The following is a description of a gene set: Mouse Gene Set: GOMF_PROTEIN_HOMODIMERIZATION_ACTIVITY Binding to an identical protein to form a homodimer. studied in species Mus musculus, and this is the list of marker genes: Fbxo4, Tmem192, Rnf8, Nr2c1, Diaph3, Ugt1a7c, Nectin2, Arnt, Hspb8, Nog, Gyg1, Syt6, AY761185 (cDNA sequence AY761185), Nacc2, Prkra, Hnf1b, Mid2, Syt3, Lpl, Uxs1, Cer1, Adra2c, Trim12a, Rrm2, Defa5, Ugt1a8, Lrp4, Stk4, Ugt1a6b, Tpst2, Gnptg, Idh1, Fut9, Grm6, Defa42, Pdlim4, Cryl1, G6pdx, Pon1, Pdcd10, Pank1, Schip1, Cars1, Lct, Sting1, Cep43, Top2a, S100a10, Acot7, Birc5, H2-M10.6, Ntrk1, Mdh2 (NCBI Gene Id 17448), Kyat1, Ceacam1, Wwtr1, Wars1, Ceacam2, Pgrmc1, Stub1, Flrt3, Pex11b, Carnmt1, S100a5, Slk, Ide, Psph, Sds, Ucp2, Blm, Hsd11b1, Eno1, Sod1, Tenm2, Slc5a5, Col9a3, Vps25, Calcoco2, Chuk, Hand1, Zbtb7b, Defa37, H2-Q2, Trim30b, Gen1, Il17a, Usf2, Eif2ak1, Ttn, Sgta, Rabl3, Kit, Glce, Rtn4, Gucy2e, Jam3, Stard3, Masp1, Defa17, Amhr2, H2-M2, Oxa1l, Sgtb, Tpst1, Dars2, Ang2 (angiogenin, ribonuclease A family, member 2), Cacybp, Akt1, Abcd1, Jdp2, Park7, Myom1, Abcg3, H2-Q7 (histocompatibility 2, Q region locus 7), Miga1, Kcnip3, Aox3, Gadd45a, Ces1c, Mmut, Nadk2, Nkx2-5, Trnt1, Aoc1l1, Pcyt1a, Bnip3l, Trex1 (NCBI Gene Id 22040, three prime repair exonuclease 1), Slc25a14, Cby1, Miga2, Tbx15, Hpgds, Tpr, Xpa, Septin12, Sppl2a, Fmr1, Syt4, Shmt1 (serine hydroxymethyltransferase 1 (soluble)), H2-M10.1, Gbp5, Defa22, Zdhhc3, Supv3l1, Bhlhe40, Mff, Chmp4b, Mstn, Adrb3, S100z, Defa2, Flt1, Gsta13, Csf1r, Cadm1, Mtmr1, Adrb2, Zbtb1, Csf1, Hnf4a (hepatic nuclear factor 4, alpha), Dgkd, Pkd2, Dgat2, Defa43, Hps4, Septin5, Thap1, Acp3, Cda, Eno1b, Stc2, Ptprt, Sohlh2, Efr3a, Stk19, Dgcr8, Sppl2c, Cltrn, Tfrc, Mad2l1, Defa27, Rabep1, Gsta2, Pitx2, Xcl1 (NCBI Gene Id 98422), Cd247, Hmox1, Stom, H2-Q1, Tenm1, Atp2a1 (NCBI Gene Id 11937), Jaml, Trim5, Gstm1, Aoc1l3, Zdhhc2, Syne1, H2-M3, Tnnc1, Mgat4a (NCBI Gene Id 320137), Abcb9, Ugt1a6a, Acsl6, Timm9, Banf1, Cd4, Impa1, Tbx18, Tymp, Cisd2, Kif20b, Naa60, Terf1, Dck, Cep135, Pdk2, Pecam1, Sppl2b (signal peptide peptidase like 2B), Pon3, Slc25a27, Abcg4, Defa3, St3gal2, Bok, Xpnpep3, Axin1, Dscaml1, Fzd4, Creb3l3, Chmp1a, Cln6 (NCBI Gene Id 76524), Slc11a1, Cant1, Defa31, Pkm, Appl2, Mbl1, Kynu, Vil1, Tssk4, Smim1, Fzd9, Bax, Card9, Ikbkg, Defa20, Zbtb16 (zinc finger and BTB domain containing 16), Gdf15, Rab11fip4, Apoa1, Thrsp, Apoa2, Npc1l1, Terf2, Thbs1, Fcer1g, Defa41, Tmigd1, H2-Q6, Setmar, Odc1 (NCBI Gene Id 18263), Nrf1, Adipoq, Pdgfa, Paxx, Dnph1, Aldh1a3, Abcd3, Nr0b2, Phb2, Defa29, Slit2, Tyms, Tyrobp, Cenpf, Gpd1l, Csn1s2b, Camk2a, Snrpc, Ripk2, Psmf1, Map3k13, Ext1, Tpi1, Amelx, Nqo2, Thra, Rdh5, Kcnn4, Sirt6, S100a1, Bst2, Ssbp1, Mkln1, H2-M10.4, Smchd1, Rbm11, Tbc1d22a, Golga5, Defa36, Srm, Cdsn, Nr2f2, Pip4k2a, Bmpr1a, Trex2, Kcnn2, Ugt1a9 (NCBI Gene Id 394434), Rasip1, Bnip3, Tarbp2, Atf2, Smad4, Stk10, Chrna7, Snx6, Chek2, Aimp1, Crppa, Myh9, Gimap7, Dab2ip, Irak2, Col9a1, Tbx1, Ang4, Grpel2, Ano1, Dnm1l, Syndig1, Actn4, Xpnpep1, Tars2, Prph2, Izumo3, Pou3f3, Daxx, Dusp29, Camk2d (NCBI Gene Id 77170), Prps2, Mmachc, Ang, Pdcd6ip, Morc2a, Pth1r, Tenm3, Tpcn1, Tert, Cat, Apoa4, Dnttip1, Enpp1, Zbtb38, H2-M5 (histocompatibility 2, M region locus 5), Dclre1b, Uba5, Rraga, Aoc1, Psap, Aldh3a2, Agxt, Gca, Nfs1, Tyw5, Ahr, Ankrd11, Endog, Ctbp1, Gstz1, Mecom, Inhbb, Hspb1, Cebpa, Fgfr1, Npm1, Nr0b1, Mef2d, Wrn, Ccdc103, Nectin3, Nr6a1, Ptpa, Mixl1, Xdh, App (amyloid beta precursor protein, NCBI Gene Id 319425), St6gal1, Gdnf, Txn1 (thioredoxin 1), Nudt16, Ficd, Casq2, Rap1gap, Gsta1, Mvd, Bcl11a, Cgas, S100a13, Cyp2r1, Dpp4, Dst, Ccl5, Pex7, Glb1, Epm2a, Hip1r, Tgfb2, Dapk3, Slc4a1, Nos2 (NCBI Gene Id 18126), Mtpap, Glipr2, Hes1, Tenm4, Cryab, Defa32, Ikzf3, Qtrt1 (queuine tRNA-ribosyltransferase catalytic subunit 1), Lrp6, Ghr, Pank3, Defa25, Crym, Ano6, Bak1, Srr, Clec2f, Dpyd, Npr3, Bcl10, Ercc5, Defa40, Mgat2, Gid8, Aox4, Ugt1a5, Add2, Ambp, Defa28, Alx1, Ern1, Spr, Trim9, Trp53bp2, Ruvbl2, Zfp397, Slc51a, Jchain, Tesc, Impa2, Iscu, F11r, Rab11fip2, Papss1, Rag1 (recombination activating 1), Trim30d, Apoe, Trim8, Fxr2, Irak1, Scarb2, Dnm1, Dpy30, Hsp90ab1, Rab11fip3, Aoc1l2, Zfp318, Tpm4, Tyrp1, Pln, Defa24, Cep131, Gbp2, Myom3, Atic, Ptpro, Gstm3, Exd1, H2-D1, Syt10, Fech, Psmd7, Pdgfra, Camk2b, Atg7, Mmaa, Foxp3, Pheta2, Cubn, Rbm44, Ect2, Slc33a1, Rpe, Srf, Rela, Sp100, Grhpr, Tpm1, Ndp (NCBI Gene Id 236713), Naga, Mfsd1, Bard1 (BRCA1 associated RING domain 1), Pdgfc, Cited1, G6pd2, Abcb10, Als2, Nudt21, H2-K1, Aox2 (NCBI Gene Id 213043), Hand2, Pld6, Il17f (NCBI Gene Id 96930), H2-M10.2, Tpm2, Hnf1a, Flna, Padi2, Trim30c, Cib2, Map3k11, Ces1b, Hook1, H2-Q10, Cylc1, Lrrfip1, Hsd17b1, Sh3glb1, Rchy1, Trim37, Mapk4, Hpd, Col9a2, Hars1, Abcb7, Elavl1, Nrbp1, H2-M11, Rnf40, Chka, Fgfr2, Adra2a, Gstm4, Clcn1, Eea1, S100a6, Tlr9, Klhl7, Gldc, Tcf3, S100b, Gale, Mzf1, Defa34, Serpinf2 (serine (or cysteine) peptidase inhibitor, clade F, member 2), Omg, Ntrk2, Cbs, Ptgs2, Irf3, Pheta1, Nr4a3, Abcg1, Kmt2a, Il6ra, Bcas1, Agr2, Atf3, Cpq, Rbpms, Defa39, Pdcd6, Defa26, Acox1, Prmt2, Wdr54, Kcnh2, Acox2, Snf8, Mag, Srgap2, Hhex, Hes6, Asmt, Hip1, Pafah1b2, Vapb, Stat3, Acod1, Nudt5, Nectin1, Sox6 (SRY (sex determining region Y)-box 6), Dgkh, Defa23, Tap2, Cdadc1, Vapa, Sp1, Defa35, Abcd2, Hif1an, Pdxp, Chmp4c (charged multivesicular body protein 4C), Zfp365, Mgll (monoglyceride lipase), Cr2, Hesx1, Irak3, Lrrk2, Erp29, Foxp2, Hsp90aa1, H2-T22, Hmgcs1, Twist1 (twist basic helix-loop-helix transcription factor 1), Bhlhb9, Nod1, Add1, Stat1, Morc2b, Galm, Prdm9, Ppcs (NCBI Gene Id 67987), Mtus2, Grpel1, Ocm (oncomodulin), Vwa1, Fxr1, Defa30, Parp1, Exd2, Coq9, Sohlh1, Aox1, Nudt16l1, H13, S100a16, Tox3, Snx9, Ang5, Actn1, Siah1a, Scly, Pml, Zfp174, Cav2 (caveolin 2), Lhpp, Bnip3l-ps (BCL2/adenovirus E1B interacting protein 3-like, pseudogene), Gstm2, Hvcn1, Stk26, Kyat3, Hoga1, Pon2, Gss, Stard3nl, Runx1, Trim12c, Itpr1, Sephs1, Erbb4, Adam10, Pycard, Ggct, B2m, Adcy8, Cst7, Flt4, Efemp2, Camk2g, Mtcl1, Izumo1, Hsd17b4, Smad3, Tap1, Cidea, Rom1, Prmt8, Pafah1b3, AU021092, Bloc1s6, Eprs1, Defa21, Xkr4, Sdcbp2, Appl1, Slc3a2, Myod1, Fap, Cpox, S100a11, Ang6, Gstm7, Pdgfb, Ikbkb, Pdxk, Gtf2a2 (NCBI Gene Id 83601), Cebpb, Ldb1, Alpi, Cnot9, Stk25, Sppl3 (signal peptide peptidase 3), Pde2a, Glud1, Bltp3b, Eng, Tmem266, Gzma, Tpd52l2, Gopc, Usf1, Grem1, Knstrn, Slc39a13, Zhx3, Tkt, Defa38, Ext2, Ugt1a1, Msi1, Inpp5f, Grhl1, Snx2, Creb3 (NCBI Gene Id 97162), Plekhb1, Bhlhe41, Drosha, Kars1, Stat5b, Cisd1, Man2a1, Gstm5, Naaladl1, Tsc2, Gbp3, Sars1, Vps4b, Pex11a, Lyrm4, Zbtb4, Pirb, Upb1, Ugt1a2, Pnpo, Tmem132a, Tfap4, Gch1, Snx1 (NCBI Gene Id 56440), Fzd1 (NCBI Gene Id 14362), Tfap2b, Tyr, Trpc6, Map3k5, Prps1, Acvr1, Nlgn4l, Col2a1, Gsta5 (glutathione S-transferase alpha 5), Map3k12, Rbpms2, Trim30a, Ddit3, Qtrt2, Cadm3, Klhl2, Sfpq, Pip4k2b, Coro1a, Mid1, Csn1s2a, Casr (calcium-sensing receptor), Neurog1, Slc26a5, Mthfd1l, Rack1, Commd1, Slc8b1, Plek, Yars2, Tpd52, Fbln5, Txnrd2 (NCBI Gene Id 26462), Ece1, Tppp, Nlrc4, Ache, Slc30a8, S100a11-ps, Zhx2, Fibin, Ephx2, Il17d, Tsg101, Ccdc88a, Ripk1, Aadat, Gla, Hspb6, Gbp2b, Gstm6, Heyl, Cep57, Gpd1, Cip2a, Tpd52l1, Ugt1a10, Mlx, Muc13, Msh2, Timm10, Abcg2, Mme, Ccdc66